Given this list of marker genes SLC25A2, SLC38A9, SLC7A7, SLC38A4, SLC25A15, SLC22A2, CLN3, SLC7A2, SLC7A1, SLC47A1, SLC66A1, SLC7A3, SLC25A29, SLC11A1, SLC7A6, here is a description of the gene set: The directed movement of L-arginine across a membrane. Human Gene Set: GOBP_L_ARGININE_TRANSMEMBRANE_TRANSPORT species: Homo sapiens